The following is a description of a gene set: Mouse Gene Set: REACTOME_GP1B_IX_V_ACTIVATION_SIGNALLING species: Mus musculus GP1b-IX-V activation signalling, and this is the list of marker genes: Gp9, Vwf, Raf1, Gp1ba, Col1a1 (NCBI Gene Id 217123), Gp1bb, Gp5, Src, Flna, Col1a2, Pik3r1, Ywhaz